The following is a description of a gene set: C57Bl/6 wild-type and STAT6 KO mice were used to study PPARg and IL-4 signaling. Bone marrow of 3 mice per group was isolated and differentiated to macrophages with M-CSF (20 ng/ml). 20 ng/ml IL-4 was used to induce alternative macrophage activation and 1 uM Rosiglitazone (RSG) was used to activate PPARg. From each mouse 4 samples were generated: 1. M-CSF, 2. M-CSF+RSG, 3. IL-4 and 4. IL-4+RSG. All compounds were added throughout the whole differentiation process, and frech media was added every other day. Control cells were treated with vehicle (DMSO:ethanol). After 10 days, RNA was isolated and gene expression profiles were analyzed using Mouse Genome 430 2.0 microarrays from Affymetrix. species: Homo sapiens Genes down-regulated in bone marrow-derived macrophages with STAT6 knockout: control versus treated with IL4. Human Gene Set: GSE25088_CTRL_VS_IL4_STIM_STAT6_KO_MACROPHAGE_DN from publication Szanto A, Balint BL, Nagy ZS, Barta E, Dezso B, Pap A, Szeles L, Poliska S, Oros M, Evans RM, Barak Y, Schwabe J, Nagy L (PMID 21093321), and this is the list of marker genes: NAPSA, MRPL2, NUPR1, DUSP15 (dual specificity phosphatase 15), GTF3A (general transcription factor IIIA), DTNB, GSTM2, GNA11, ALKBH4, EVI5, SERPINE2, PRORP, EPS8L2, CPEB3, REXO5, ENDOD1, ABCB7, ITGA3, LAT2, ACP6, COMMD7, NIPSNAP1, TMEM161A, PAK1, TMEM255B, ZNF221, FRK, COPG2, MIR646HG, ACTN1, CYP4F8, PLEKHN1, TRIM7, TSPAN4 (NCBI Gene Id 7106), C19orf81, SIRPG, IFI27, MRFAP1 (Morf4 family associated protein 1), SMYD3, DRAM2, CT75 (cancer/testis associated transcript 75), SLC12A4, EMC10, UBE2J1, DUXAP10, KIF3C, B4GALT7, TNFRSF4, CEACAM21, SPATA25, TXNDC15 (thioredoxin domain containing 15), SNX2, SNX18, PPP2R3B, RBPJ, KCNJ15 (NCBI Gene Id 3772), ENSG00000261327 (novel transcript), DHX9-AS1, TAB1, EIF2D, TMEFF1, CLLU1, ZC3HC1, IL2RA, CELSR2, GSS, TRIM46, CEP43, ZNF787, LZTFL1, METRN, RTN4IP1, TRIB1, CRIP1, HKDC1, DHRS3, MAGEB6, MCF2L2, NMUR1, IL32, RITA1, SLITRK1, ZNF254, PDE4A, GLIS2, MACROD1, BCAP29, FZD7, TGFB1I1, SNAPC2, MON1A, NT5C3B, CD69, P2RY10, LSM11, ALPG, ZNF768, GBGT1, RALY, IGHM, ABHD16B, TRBC1, CD7, FCGRT, FBP1, MYL5, ZNF778, MIR3976HG, FZD1, LINC01833, PRRT1, KCNJ5-AS1 (NCBI Gene Id 219833), FAM238C, RNF130, MED9, TMEM230, PLAAT3, AFAP1L2, PRIMA1, EPSTI1, KCNC3, COMTD1, IL5, EVPLL, DUSP16, RASSF8-AS1, DHTKD1, HDX, CIMAP1B, TTLL1, HSD17B12, HIC1, TUFT1, C1QTNF6, RPL13, CRAT, C10orf71, ARMC6, MICAL2, GALR2, ZNF415, PSRC1, BSCL2, DPY19L1P1, TM4SF20, COQ6, GZMB, PPDPF, CASTOR3P, LINC00488, NAT8B, TAMM41, MANEAL, PABPC3, CAST, CYP8B1, HEXA, BDH1, HBEGF, GAB2, HMX2, OTOS, SNX5, GPR37L1, OR2C3, YJEFN3, PENK, NIT1, OXLD1, LINC00856, SH2D2A, BABAM2, PDE9A, AVL9, GPR161, SPAG5-AS1, SERPINH1, EVI5L, MXD3, FES, BCKDHA, SPSB2, FXN, MYPOP, FOXP1-IT1, GRAPL, CLIC4, DBP, AKR7A2, LAMB2P1, SELE (NCBI Gene Id 6401)